The following is a description of a gene set: A multisubunit guanine nucleotide exchange factor which catalyzes the exchange of GDP bound to initiation factor eIF2 for GTP, generating active eIF2-GTP. In humans, it is composed of five subunits, alpha, beta, delta, gamma and epsilon. studied in species Mus musculus Mouse Gene Set: GOCC_EUKARYOTIC_TRANSLATION_INITIATION_FACTOR_2B_COMPLEX, and this is the list of marker genes: Eif2b5, Eif2b1, Eif2b2, Eif2b3, Eif2b4